The following is a description of a gene set: from publication Chen Y, Wang X (PMID 31504780) Human Gene Set: MIR4791 Genes predicted to be targets of miRBase v22 microRNA hsa-miR-4791 in miRDB v6.0 with MirTarget v4 prediction scores > 80 (high confidence targets). studied in species Homo sapiens, and this is the list of marker genes: PSMC2, PCDH9, EFEMP1, NT5E, EPM2A, PHIP, ERLIN2, CYP24A1 (NCBI Gene Id 1591), PLEKHA5, DARS1, USP49, NOTCH2, UBE2B, SGCD, CACNA1D, ZNF197, PATL2, TRAF5, IRF2BP2, PGM2L1, BNIP3L, FAM210B, OCRL, SLC25A40, FTO, SLC23A2, OPALIN (oligodendrocytic myelin paranodal and inner loop protein), ATP5MF, CADM1, TMEM265, PHACTR4, EFCAB14, PTCHD4, BCOR, SLITRK1, CTCFL, RLIG1, TRIM44, ALAS1, LGI1, GPX5, ERP27, STAU1, S1PR1 (sphingosine-1-phosphate receptor 1), MYLIP, GCH1, TENM1, MB21D2, SLC41A2, MBNL2, CHRM5, DVL3, NFASC, ZIC3, VTCN1, FBXL17, CRYBG3, MGA, CDPF1, ADGRE3, MAL2, DHFR, ETV1, EEIG2, TCAIM, ITGA2, IL11, UTP25